Given this list of marker genes PRF1, POMC, F2RL1, CXCL6, ARG1, here is a description of the gene set: Human Gene Set: GOBP_REGULATION_OF_KILLING_OF_CELLS_OF_ANOTHER_ORGANISM Any process that modulates the frequency, rate or extent of the killing by an organism of cells in another organism. species: Homo sapiens